The following is a description of a gene set: species: Homo sapiens A process that activates or increases the frequency, rate or extent of cell proliferation in the bone marrow. Human Gene Set: GOBP_POSITIVE_REGULATION_OF_CELL_PROLIFERATION_IN_BONE_MARROW, and this is the list of marker genes: LEF1, FGFR2, HMGA2, SHC1 (SHC adaptor protein 1), MIR27B (NCBI Gene Id 407019), PTH